The following is a description of a gene set: from publication Dudziak D, Kamphorst AO, Heidkamp GF, Buchholz VR, Trumpfheller C, Yamazaki S, Cheong C, Liu K, Lee HW, Park CG, Steinman RM, Nussenzweig MC (PMID 17204652) studied in species Homo sapiens Human Gene Set: GSE6259_CD4_TCELL_VS_CD8_TCELL_UP Dendritic cells (DCs) process and present self and foreign antigens to induce tolerance or immunity. In vitro models suggest that induction of immunity is controlled by regulating the presentation of antigen, but little is known about how DCs control antigen presentation in vivo. To examine antigen processing and presentation in vivo we specifically targeted antigens to the two major subsets of DCs using chimeric monoclonal antibodies. Unlike CD8+ DCs that express the cell surface protein CD205, CD8- DCs, which are positive for the 33D1 antigen, are specialized for presentation on MHC class II. This difference in antigen processing is intrinsic to the DC subsets and associated with increased expression of proteins associated with MHC processing. Genes up-regulated in T cells: CD4 versus CD8., and this is the list of marker genes: CPXM1, PREP, CH25H, ADAMTS2, TIMM23, SPATS2, KIF23, NETO2, PRKD1, CCL7, ANGPTL4 (NCBI Gene Id 93954), EFEMP2, CEP55, ATP2B4, CLIP3, PLAUR, GPM6A, FLNC, NAT10, WDR83OS, DSEL, KYAT3, NHP2, SLC7A6, NDC1, CAVIN1, CTSD, MICALL2, IL6, TSC22D1, DCTD, EIF3L, HSPB1, C1orf21, CACNB3, SCHIP1, NPDC1, ZBED3, LAYN, DAZAP1, SMO, GAS1, NPAS3, RRP9, TSKU, ARHGAP23, TCN2, CCL22, MPZL2, EPHB4, GPT2, DCBLD2, PFAS, TPSB2, P3H4, GPD2, TRIP6, CALD1, S100A16, DDR2, BBS2, PRDX2, ADGRL1, TEAD2, SRGAP1, CXCL13, TKFC, LTBP2, CENPE, ZBTB20, COLEC12, WWTR1 (WW domain containing transcription regulator 1), PTPN14, RHOJ, LRP8, NT5C3B, RPN2 (NCBI Gene Id 6185), RND1, TAFA5, MMS22L, ADAM12 (ADAM metallopeptidase domain 12), TMEM108, PRR11, CCNA2, MANBA, SLIT3 (NCBI Gene Id 6586), LGI2, ELOVL6, RTN1, MYH10, FABP7, MDN1, BCKDHB, IGFBP6, PA2G4, JAM3, ITGAX, EFNB2, FAT1, KANK2, TRIM24 (NCBI Gene Id 8805), MCM5, CKAP2L, SLC25A13, EPHX1, PTPRS, NOP16, GATA6, LGR4, PLEKHH2, RGS16, GORASP2, PCOLCE, LIX1L, RPS10, JPT2, SEMA4B, RASL11A, ESYT2, PRMT7, LAMB2, EPAS1, COL24A1, SPRR2E, H4C4, CTU2, FAM162A, CSF1, CHSY1, EMILIN2, SEC61G, NXN (nucleoredoxin), ALDH1A2, SERPINF1, BNC2, CHL1, PLCG1, FGFR1, EGLN3 (NCBI Gene Id 63900), USO1, ADPGK, ANKRD1, SC5D, TNFAIP6 (TNF alpha induced protein 6), CNPY2, CD33, SORT1, PRXL2C, BUB1B, GPX8, LAMA5, PLXNA4, TUBB2A, FBLN1, ZMAT3 (NCBI Gene Id 64393), AEN, THAP12, HSP90B1, COBLL1, PHLDA3, NUP35, FLT4, FSTL1, PDLIM7, GJB3, VEGFD, TIMP1 (TIMP metallopeptidase inhibitor 1), TSPAN4, TSHZ2, POLR1B, IL22RA1, SHB, IL1A, SLC1A2, BMP2, MCEMP1, ELOVL5, XRCC5, NPL, EZH2, PTGR3, TAGLN, GPRC5B, OGN, RPLP1, H2AC15, RPL36A